The following is a description of a gene set: species: Homo sapiens Catalysis of the reaction: ATP + H2O = ADP + phosphate, which promotes unfolding of protein substrates, and channel opening of the core proteasome. Human Gene Set: GOMF_PROTEASOME_ACTIVATING_ACTIVITY, and this is the list of marker genes: PSMC5 (proteasome 26S subunit, ATPase 5), PSMC2, PSMC6, PSMC3, PSMC4, PSMC1